The following is a description of a gene set: Mouse Gene Set: GOBP_REGULATION_OF_NEURON_PROJECTION_REGENERATION studied in species Mus musculus Any process that modulates the rate, frequency or extent of neuron projection regeneration, the regrowth of neuronal processes such as axons or dendrites following their loss or damage., and this is the list of marker genes: Rtn4, Scarf1, Map2k2, Igf1r, Ptprs, Kremen1 (NCBI Gene Id 84035, kringle containing transmembrane protein 1), Neo1, Ptprf, Thy1, Cers2, Pten, Pum2, Cntf, Hgf, Epha4, Braf, Rtn4r, Lrp1, Tnr, Xylt1, Fkbp1b, Diaph2, Ptn, Rgma, Nrg1, Adam17, Lrig2, Ntrk3, Map4k4, Flna, Ndel1, Stk24, Rtn4rl1, Map2k1, Klf4, D130043K22Rik, Omg, Diaph1, Rtca, Grn, Prrx1, Inpp5f